The following is a description of a gene set: from publication Chen Y, Wang X (PMID 31504780) species: Homo sapiens Genes predicted to be targets of miRBase v22 microRNA hsa-miR-584-5p in miRDB v6.0 with MirTarget v4 prediction scores > 80 (high confidence targets). Human Gene Set: MIR584_5P, and this is the list of marker genes: PPIL1, ELL2, POLR1F, SETD5, CCNC, CADPS, ALPK1, ANKLE1, GABRA4, HSD11B1, PTCH2, ADNP2, ZNF512, TRAF3IP2, TMEM212, MTRF1, ENAH, CCDC152, USP6NL, PPFIA2, PSMF1, AIDA, ACYP2, FOXA1, SH3PXD2A, LRRIQ3, ZNF614, SPOPL (NCBI Gene Id 339745), LINC02801, SLC35D3, PRRX1, NUDCD2, MYRIP, BPNT2, SRP72, VPS41, SNTG1, PABIR2, DSG3, RAP2A, NCOR1, KMT2A, NAA30, MEX3B, TBRG1, XPO7, CENPQ, AVPR1A, PRPF19, CAVIN4, CD200, SLC2A13, PDXDC1, EIF2AK1, RUNX2, PDHA1, FREM1, SLC25A23, THBD, POGLUT1, TRDN, GNG12, TCAIM, DHH, ZNF432, PHACTR1, CHORDC1, CNOT9, PKD2, GRID2, LRP11, CALCA, GBP5, EXPH5, SIGLEC10, TMX1, ZNF583, GALNT15, PIGK, NPHP1, YKT6, PPM1A, DAND5, HDAC1, TTC22, HBD, ANGPTL5